The following is a description of a gene set: Human Gene Set: GSE15330_HSC_VS_GRANULOCYTE_MONOCYTE_PROGENITOR_IKAROS_KO_DN from publication Ng SY, Yoshida T, Zhang J, Georgopoulos K (PMID 19345118) Genes down-regulated in IKZF1 knockout: hematopoietic stem cells versus granulo-monocyte progenitors. studied in species Homo sapiens Regulation of lineage potential and transcriptional priming by Ikaros. New insight is provided into a bivalent regulation of lineage priming in the HSC and its lympho-myeloid restricted progeny the LMPP by the lymphoid lineage-determining factor Ikaros Whereas Ikaros is responsible for the activation of a cascade of lymphoid expression programs and for the establishment of lymphoid potential from the HSC to the LMPP it is also responsible for the repression of stem cell and erythroid genetic programs that are incompatible with further lineage restrictions emanating from the LMPP, and this is the list of marker genes: KLHDC3, BMI1, TFB1M, NR4A1, GLI2, FLCN, MLST8, RGS2, PSMD10, SRRT, SLAIN1, PTGER4, CYB5R1, ASAP1, SDF4, SLFN12L, HSD17B10, CDK1, NEK9, IGF2BP3, RARS1, ASB11, IARS2, CSK, CCT5, SUCLG1, MCOLN2, BLMH, CLYBL, RTF2, NOA1, PURA, PLEKHG6, CD52, ECD, LYRM2, THY1 (NCBI Gene Id 94105), SRSF6, NPTXR, SLC30A9 (solute carrier family 30 member 9), ADPGK, SELENOH, ELP3, TRIM54, GNAQ, NUP43, MSRA (NCBI Gene Id 4482), GNPAT, BIN3, FCGR2A, PARVG, HOXB3, SLC25A29, NSG2, MESD, UNK, EP400, PLPP1, MCTS1, HOPX, LRRIQ4, ZYG11B (zyg-11 family member B, cell cycle regulator), ST6GAL1, EXOSC10, TP53RK, RAB34, DOCK2, RAB8B, RIPK2, RCN1, FAAH, MRPS2, HMG20A, PSPH, CD40LG, GTF2E2, EIF3C, VIRMA, FAM114A2 (family with sequence similarity 114 member A2), CCNK, PTPRC, DLG3, SELENOS, MRM2, GLRX, SLC9A8, PACSIN1, TPRKB, PLAAT3, ADSL, ELAVL3, DPYSL2, PDK1, SLAMF1, GLOD4, HBP1, HMGCS1, ADH1C, IFI27L2, TRAP1, CD3G, SSRP1, SWAP70, WNT16, GC, ADAMTS10, CMBL, EXTL3, FAF1, SYNE2, GLCE, OSBPL9, INTS6, DPP8, ABRACL, KAT6A, CHKB, LSM10, COPB1, PFN1, TBCD, DBNL, MSI2, KPTN, GPAA1, COQ9, ZNF354B, DGUOK, TSC22D1, NAMPT, GLMN (NCBI Gene Id 11146), LAG3, SNX19, SF3A2, CA2, OR7C1, KAT2A, COMTD1, PYROXD1, NUDT4, EPHX1 (NCBI Gene Id 2052), POU2F2, MTARC2, INTS6L, GEMIN6, TACC2, THOC6, RYR1, USP47, PRMT3, EIF4E, CSAD (NCBI Gene Id 51380), LIMD1, MND1, CFAP141, HMGN3, GRK1, QPRT, TCF7, CBR4, PBDC1, TSPAN3, DHRS3, THOC7, TMEM126A, ASH2L, TSR2, IMMT, VPS25, BSPRY, OCIAD1, MANBA, PPP2R5A, STAG2 (STAG2 cohesin complex component), COX7A2L, NME7, STK39, ID3, PHPT1, ORMDL1, PPCDC, SLFN13, TNNT2, PTMS, RPAP1, ADH5, GPR12, MYLIP, B3GNT2, PGRMC1, NRDE2, HPCAL1, STAT4, PACS2, APOE (NCBI Gene Id 99), DLX1, SMPDL3A, HOMER1, FYN, SYTL2